Given this list of marker genes SLC25A37, RRP9, RNPS1, MOB3C, SREBF2, LIMS3, SLC1A4, ELAVL1, OSBPL6, LILRA1, SLC37A1, CASP7, HSBP1, PIGL (NCBI Gene Id 9487), DNA2, LONP1, AMBP, POLR1E, DYNLT1, PYCR2, NIT2, RPS2, PSMD13, TMEM170A, PSMC3, RASGEF1B, PSMB4, TRIM21, TMPRSS5, TCF12-DT, CFAP68 (cilia and flagella associated protein 68), DPAGT1, OGFOD1, NOC4L, NOP2 (NOP2 nucleolar protein), NSDHL, RCC2, MPO, EIF4G3, TRG-AS1, AFAP1, BST1, BABAM2, NANS, EIF4H, B3GALT6, MOV10, HYKK, TRAP1, C11orf21, NECTIN2, PSMD3, GLT1D1, XPO5, FKBP15 (FKBP prolyl isomerase family member 15), TMEM41B, LDLR, ZFP57 (NCBI Gene Id 642028), STOML1, IFRD2, BTN3A2, CD33, ABT1, LILRA5, HLA-DQB1, ANGEL1, POLR3D, AK4, LINC00929, POC1A, SRPRB, BUD23, LGALS3BP, TXN2, IL27RA, KCNE5, PTAFR, ZDHHC4, NAGA, PSMB5, RPF2, TMEM140, PDLIM7, POLB, ALX1, DSE, OMP, GPR62, ZNF668, HCAR3, EIF2B4, MTCP1, ARL1, NDUFAF4, ENTREP3, CC2D1B, EID3 (NCBI Gene Id 493861), DAP, P2RX6, ETV5 (NCBI Gene Id 2119), LILRB4 (leukocyte immunoglobulin like receptor B4), KIAA0930, ZNF236, PRIM1, BZW2, COG5, AARS1, SLC25A32, ATF5 (activating transcription factor 5), LINC01845, PFKFB4, EDEM1, HVCN1, TMEM229B, DIABLO, IFNA16, DIP2C-AS1, PSMD1, CCR5, DENND1A, IL36G, ST3GAL5, PSMA5, ATP6V1E1, COL9A2, ATP10B, KTI12, SETBP1, ALAS2, RUVBL1, LY6S-AS1, PPA1, PNP, KNG1, VPS51, TIMM9, FCHO1, UQCRFS1, QPCT, WDR77 (NCBI Gene Id 79084), RNLS, AIFM2, MSMO1 (methylsterol monooxygenase 1), THOC6, PTTG3P, ZCWPW1, PTPA, EIF6, AGAP11, TRABD, PNOC, TBC1D1, DLAT, PRPF19, NHLRC3, PRELID1, USP6NL, COX7B, CMTR1, ZNF391, LCTL, LYSMD2, SLC25A45, COL28A1, TGM2, TMEM235, SP110, CFAP54, ASB12, GDPD5 (glycerophosphodiester phosphodiesterase domain containing 5), DTX3L, BEX5, MRPL46, AGTR1, NSMCE4A, MORC2-AS1, DNAJA4, STYXL2, HYOU1, MTHFD2, EXOSC5, KARS1, CCDC181, RAPGEF2, EOLA2, XKR8, CEBPA, UBB, SUSD6, C14orf39, DUSP5, SEC61G, GORASP2, NOPCHAP1, ATP6V1G1, TFB1M, here is a description of the gene set: from publication Hu X, Chung AY, Wu I, Foldi J, Chen J, Ji JD, Tateya T, Kang YJ, Han J, Gessler M, Kageyama R, Ivashkiv LB (PMID 18976936) studied in species Homo sapiens Human Gene Set: GSE11864_CSF1_VS_CSF1_IFNG_IN_MAC_DN Gene expression analysis of freshly isolated CD14+ human monocytes and monocytes cultured in the presence or absence of interferon (IFN) -gamma for 24 h and then stimulated with Pam3Cys, a Toll-like receptor (TLR) 2 ligand, for 6 h. Results provide insight into mechanisms by which IFN-gamma reprograms early macrophage differentiation and subsequent response to TLR ligands. Genes down-regulated in comparison of macrophages cultured with M-CSF versus macrophages cultured with M-CSF and IFNG.